The following is a description of a gene set: Human Gene Set: DESCARTES_FETAL_HEART_SATB2_LRRC7_POSITIVE_CELLS Marker genes curated from the annotated cluster as represented in the Descartes Human Gene Expression During Development database. studied in species Homo sapiens from publication Cao J, O'Day DR, Pliner HA, Kingsley PD, Deng M, Daza RM, Zager MA, Aldinger KA, Blecher-Gonen R, Zhang F, Spielmann M, Palis J, Doherty D, Steemers FJ, Glass IA, Trapnell C, Shendure J (PMID 33184181) The gene expression program underlying the specification of human cell types is of fundamental interest. The study authors generated human cell atlases of gene expression and chromatin accessibility in fetal tissues. For gene expression, the study authors applied three-level combinatorial indexing to >110 samples representing 15 organs, ultimately profiling ~4 million single cells. The study authors leveraged the literature and other atlases to identify and annotate hundreds of cell types and subtypes, both within and across tissues. Our analyses focused on organ-specific specializations of broadly distributed cell types (such as blood, endothelial, and epithelial), sites of fetal erythropoiesis (which notably included the adrenal gland), and integration with mouse developmental atlases (such as conserved specification of blood cells). These data represent a rich resource for the exploration of in vivo human gene expression in diverse tissues and cell types., and this is the list of marker genes: CALN1, SATB2-AS1, CACNA1A, GRM1 (glutamate metabotropic receptor 1), BHLHE22, GLRA2, LINC01965, TRPC5, NXPH3, CCER2, LINC01102, CCBE1, SH3GL2, PHF21B, DLX6-AS1, LYPD6B, DPP10, FAT3, POU3F2, PANTR1, SEZ6, CACNA1E, SCD5, B3GAT1, KCNC2, TMEM158, CSMD3, POU3F3, UNC5D, LAMB2P1, SLC6A11, GPR85, SATB2, PLPPR5-AS1, NCAN, FEZF2, NTSR1, C8orf34, SLIT1, KIAA0319, GRIN2B, LRP1B, PTPRD, RN7SL481P, ARPP21, MSRA, SHISAL1, TAFA1, ADCY1 (NCBI Gene Id 449484), MIR124-1HG, PI4KAP2, MPPED1, DISP3, HES6, LHX2, TOX3, VSTM2B-DT, SCRT2, KAZN, CACNG8, DOK5, FABP7, NEUROD2 (NCBI Gene Id 4761), TBR1, ANO4, NELL2, PCDH11Y (protocadherin 11 Y-linked), HS3ST4, LINC02389, KLHL1, NTM, FOXG1, NEUROD1, MIR124-2HG, NEUROD6, DRAXIN, LINC01551, SOX11, MIR9-1HG, IGDCC3, ATP2B2, CACNA1I, KCNV1, GABBR2, LINC01122, ADGRB2, CDH4, GPR12, MIR9-3HG, GABRG1, CSMD1, SYT6, GABRG3, GRM3, GRM5, FUT9, RAPGEFL1, SLC4A10, BASP1-AS1, DAB1, LRRTM2, ZBTB18, PCDH11X, NEUROG2-AS1, MACROD2-IT1, GRM2, LMO3, PLPPR1, CSMD2, CAMKV, RORB, NKAIN2, MIR9-2HG, CADM2